Given this list of marker genes SNTB2, SGCG, ACTA2, LAMA1, SGCB, DMD, ACTA1, DAG1, ACTG2, LAMB1, LAMC1, LAMA2 (laminin subunit alpha 2), LAMA5, LAMB2, SGCZ, LAMC3, LAMA3 (laminin subunit alpha 3), DTNA, SNTG2, SGCD, ACTC1, HSPG2, SNTA1, UTRN, LAMA4, LAMB3, DRP2, ACTB, DTNB, SNTB1, ACTG1, AGRN, SGCA, SGCE, LAMC2, SSPN, here is a description of the gene set: studied in species Homo sapiens Reactome Pathway: Formation of the dystrophin-glycoprotein complex (DGC) part of: Non-integrin membrane-ECM interactions The dystrophin-glycoprotein complex (DGC, also known as DAPC, dystrophin associated protein complex) is a large, multimeric complex of proteins and glycoproteins localized near the plasma membrane that connects the intracellular cell cytoskeleton with the extracellular matrix and laminins. In muscle cells, the DGC plays roles in stabilizing the sarcolemma and transducing mechanical stimuli, but DGC complexes are found in several other cell types and tissues and play more general roles in membrane stability, signal transduction and organization of ion channels and GABA channels. While mutations in some components of the DGC are reported to make muscle fibers more susceptible to damage and lead to various types of muscle disorder such as Duchenne muscular dystrophy, Becker muscular dystrophy, limb-girdle muscular dystrophies and cardiomyophathies, DGC components have also been associated with disorders in non-muscle tissue.<br>The core of the DGC is made up of DAG1 (dystroglycan), DMD (dystrophin) and Utrophin. DAG1 is present as a non-covalently associated alpha and beta chain following cleavage at serine 654. Extracellular alpha-DAG1 (30-653) contacts the extracellular matrix by virtue of interactions between the O-linked glycosyl groups and laminins, while the transmembrane beta-DAG1(684-895) interacts with the cytosolic dystrophin protein DMD. <br>The DGC also consists of a transmembrane sarcoglycan complex consisting of four sarcoglycan (SGC) proteins and SSPN (sarcospan). On the intracelluar side, DMD and beta-DAG1 recruit membrane-associated cytosolic proteins including members of the dystrobrevin (DTN) and syntrophin (SNT) families.